The following is a description of a gene set: Human Gene Set: GOBP_OLEFINIC_COMPOUND_BIOSYNTHETIC_PROCESS The chemical reactions and pathways resulting in the formation of an olefinic compound, any compound which contains a carbon-carbon double bond (aka C=C). species: Homo sapiens, and this is the list of marker genes: SCP2, CYP11B2, STARD3, GGCX, BGLAP, H6PD, WNT4, CLCN2, DAB2, BMP6, REST, DKK3, BMP2, LHB, FSHB, ADM, CYP11B1, AKR1C3, PRKG1, SRD5A2, BMP5, GPRC6A, INHBA, DGKQ, HSD17B3, CACNA1H, CREB1, HSD17B1, DKKL1, EGR1, CYP19A1